The following is a description of a gene set: part of: rRNA processing Reactome Pathway: rRNA processing in the nucleus and cytosol studied in species Mus musculus electronically inferred by orthology from the curated human pathway This event has been computationally inferred from an event that has been demonstrated in another species.<p>The inference is based on the homology mapping from PANTHER. Briefly, reactions for which all involved PhysicalEntities (in input, output and catalyst) have a mapped orthologue/paralogue (for complexes at least 75% of components must have a mapping) are inferred to the other species., and this is the list of marker genes: Ddx52, Rps28, Bud23, Rplp2, Exosc10, Fbl, Rpl15, Rps12, Rpl3l (NCBI Gene Id 66211), Rpl23a, Rpl24, Rpl36a, Xrn2, Rpl13, Rps7, Rps4x, Rpl19, Rps2, Emg1, Rpl37a, Gnl3, Rpl7, Rps17, Rps11, Rpl11, Rpl39, Ubb, Csnk1e, Rps23, Rpl18, Rpl9, Rps25, Rpl18a, Dcaf13, Nop56, Rpp14, Fau, Rpl3, Rpl27a, Rps6, Rpl12, Nol11, Riok3, Rpl29, Pes1, Pelp1, Rps8, Rps10, Ddx21, Rrp7a, Rpl37rt, Rpl37 (NCBI Gene Id 67281), Fcf1, Rpl14, Rpl38, Rps5, Rps15, Rps26, Rps9, Nop14, Nob1, Snu13, Utp11, Senp3, Rps13, Rrp9, Rps20, Wdr43, Rpp25, Las1l, Mtrex, Rpl36al, Rps27l, Rpl27, Utp4, Ltv1, Rpl39l, Rrp36, Utp6, Nop58, Eri1, Rpl26, Rpl4, Rps18, Rps3a1, Rps24, Rpl6, Rpp21, Rps19, Pno1